The following is a description of a gene set: Human Gene Set: GOBP_REGULATION_OF_SYSTEMIC_ARTERIAL_BLOOD_PRESSURE_BY_RENIN_ANGIOTENSIN The process in which renin-angiotensin modulates the force with which blood passes through the circulatory system. species: Homo sapiens, and this is the list of marker genes: ANPEP, CTSG, SUCNR1, F2RL1, RHOA (ras homolog family member A), CTSZ, ENPEP (NCBI Gene Id 2028), CPA3, EDNRB, MRGPRD, OR51E2, PCSK5, AGT, F2R, ACE, TACR1, ATP6AP2, MME, MAS1, PRCP, AGTR2, CMA1, COMT, ACE2 (NCBI Gene Id 59272), AGTR1, REN, NDST2, RPS6KA2, NOX1, CYBA, GJA5, SERPINF2, PREP